The following is a description of a gene set: studied in species Homo sapiens Genes having at least one occurrence of the motif CNTANNNKN in the regions spanning 4 kb centered on their transcription starting sites. This matches the HOXA3 transcription factor binding site V$HOXA3_01 (v7.4 TRANSFAC). Human Gene Set: HOXA3_01, and this is the list of marker genes: SHOX2, TXNRD1, SALL1, SIM1, HTRA4, TRAF3IP2, C1QL1 (NCBI Gene Id 10882), TTLL6, GRK6, DHH, LMO2, RBMS1, LTBP1, FCHSD1